The following is a description of a gene set: Any process that modulates the frequency, rate or extent of kinase activity, the catalysis of the transfer of a phosphate group, usually from ATP, to a substrate molecule. studied in species Mus musculus Mouse Gene Set: GOBP_REGULATION_OF_KINASE_ACTIVITY, and this is the list of marker genes: Cdk12, Tlr1, Taok3, Spry4, Macroh2a1, Wnt3a, Magi3, F2, Cdc37, Cdk5, Hhex, Nf1, Cep43, Stradb, Hyal2, Ern2, Midn, Ajuba, Tlr6, Gstp1, Edn3, Ttbk1, Tenm1, Dlg1, Ptpn22, Agt, Nhlrc1, Jtb, Pdgfb, Ubash3b, Notch2, Cdk5rap3, Spry2, Cdkn2a, Fgf18, Ptpn1, Traf6, Lilrb4b, Nppa, Efna1, Lime1, Fabp4, Sirt1, Shb, Cass4, Ptprj, Adam17, Psmd10, Lrp6, Pdgfrb, Il1b, Inpp5k, Chrna3, Erbb2, Ppia, Zgpat, Nherf1, Spred1, Zeb2, Lyn, Spdye4a, Adam9, Tfap4, Stk11, Rbl1 (RB transcriptional corepressor like 1), App, Fbxw7, Hnrnpu, Epha1 (NCBI Gene Id 70581), Spdya, Cdk5r1, Prox1, Adra2a, Ntf3, Tsg101, Dusp10, Hras, Pdgfa, Mt3, Dab1, Fgfr1, Nrbf2, Rassf2, Dnaja1, Trib3, Ccnyl1, Camk1, Src, Lep, Smg8, Tab2, Nrxn1, Dab2ip, Vegfc (vascular endothelial growth factor C), Cd300a, Pkig (protein kinase inhibitor, gamma), Irgm2 (immunity-related GTPase family M member 2), Rasip1, Pycard, Ip6k2, Irgm1, Slc11a1, Thy1, Slc8a2, Rgs2, Fzd5, Abi1, Csf1, Prkrip1, Clspn, Gskip, Strada, Spry1, Snca, Htt, Tpd52l1, Map3k11, Sh3bp5, Mapk8ip3, Ccnd2, Lats2, Cblc, Sod1, Spatc1l, Mapk8ip1, Srcin1, Cdk5rap1, Sash1, Robo1 (NCBI Gene Id 436378), Cemip, Tcim, Vps25, Trpt1, Rapgef2, Agrn, Paqr3, Cab39, Trim27, Xrcc6, Angpt1, Socs5, Rb1, Fgf1, Kitl, Pde5a, Slc1a1, Rad50, Men1, Blm, Hmgcr, Ins1, Dnajc3 (DnaJ heat shock protein family (Hsp40) member C3), Ins2, Ptprb, Mmd, Map2k6, Lilrb4a, Rap2b, Adipoq, Inca1, Pik3ca, Irak1, Sez6l, Nox4, Tsacc (TSSK6 activating co-chaperone), Egf, Deptor, Apc, Cdkn1a, Tsc1, Aida, Rbl2, Chrna7, Flt1, Acp4, Tnfaip3, D1Pas1, Gadd45b, Csf1r (colony stimulating factor 1 receptor), Wwtr1, Dok7, Wnt5a, Ccnd3, Map3k5, Akt1s1, Lilra5, Wars1, Tsc2 (TSC complex subunit 2), Cdkn2c, Il3, Hmga2, Htr2b, Pkia, Ccl19-ps6, Apoe, Tnfsf11, Ptk2b, Itgb3, Ccl19, Vangl2, Ccl19-ps1, Zfp622, Gadd45a, Fcer1a, Tnfrsf11a, Errfi1, Slc8a3, Cripto, Akt1, Qars1, Map3k7, Prkag2 (NCBI Gene Id 73700), Unc119, Rps3, Tcl1, Snx9, Mcph1, Nup62, Prdx3, Ccn1, Adarb1 (NCBI Gene Id 76716), Lmo4, Gas6, Ang4, Axin1, Reln, Zfp91, Cdkn2d, Adcyap1, Arhgef5, Ccny, Dusp7, Ltf, Gadd45g, Traf2 (TNF receptor-associated factor 2), Mapt, Prkca, Pxn, Cav3 (caveolin 3), Pim1, Socs4, Fzd4, Thbs1, Dynapl1, Dynap, Dusp1, C1qtnf9, Prkch, Tirap, Adrb2, Ldb2, Dnaja3, Slamf8, Ddx3x, Tead1 (NCBI Gene Id 70301), Cox11, Ggnbp2, Prlr, Tgfb2, Ang, Syap1, Heg1, Gtpbp4, Blvra, Rap2c, Fgd4, Cib1, Map3k13, Nolc1, Mst1, Ccdc88a, Tigar, Abi2, Ntrk3, Bmp2, Hexim2, Nek10, Chi3l1, Ccl19-ps5, Chordc1, Insr, Map3k4, Neurl1a, Pik3cg, Map4k2, Pak1, Lrp8, Pdcd10, Igf1, Sez6, Nr2f2, Plk1, Pkib, Tspyl2, Mst1r, Map2k3, Npm1, Higd1a, P2rx7, Pik3r6, Chmp6, Ddr2, Gnaq, Gckr, Adar, Trem2, Adcy8, Psen1 (NCBI Gene Id 19164), Lrrk2, Ager, Nrg1, Grem1, Park7, Chp1, Cdkn2b, Fgf2, Nlrc5, Psrc1, Garem1, Cd74, Lats1, Ppp2r3c, Map3k10, Emp2 (epithelial membrane protein 2), Ankrd54 (ankyrin repeat domain 54), Aplp2 (NCBI Gene Id 11804), Drd4, Trib2, Fbxo7, Epha4, Ang6, Vldlr, Ptk6, Ldb1, Map2k1 (NCBI Gene Id 26395), Cdk5r2, Adra2b, Mllt1, Nedd9, Fgr, Ptpn2, Fgd2, Hspb1, Rhoa (NCBI Gene Id 51787), Wdr59, Cav1, Bccip, Jak2, Nf2, Ccl19-ps4, Rgcc, Ppp2ca, Tnf, Prkcd, Rtraf, Syk, Stk38, Maged1, Pten, Tnfrsf4, Irak3, Irs2, Pparg, Map3k1, Bcl10, Pkn1, Sesn2, Trib1, Rgs14, Mrnip, Mapre3, Taf7, Sfn, Gprc5a, Dbndd2, Myocd, Ptprt, Pdgfc (platelet-derived growth factor, C polypeptide), Ang5, Zfyve28, Tm9sf5, Il4, Cdkn1c, Cdc25b, Cacul1, Cimap3, Wnk4, Uchl1, Igtp, Fem1a, Ppm1e, Kat2b, Rap1a (NCBI Gene Id 99734), Egfr, Pih1d1, Adra2c, Map2k4, Abi3, Traf4, Kif14, Dusp22, Gprc5b, Xrcc5, Cd24a, Iqgap1, Als2, Cd40, Smpd1, Eef1a2, Mtor, Tpx2, Ceacam1, Uvrag, Fbn1, Gstp2, Ptpro, Ccr7, Card10, Ccl19-ps3, Il34, Stox1, Mre11a, Slc8a1, Tlr4, Daxx, Map3k12, Hgs, Prkar1a, Mvp, Sfrp5, Ulk4, Ptprc, Rasgrp1, Ang2, Gpr39 (G protein-coupled receptor 39), Ect2, Ppm1f, Sfrp1, Nprl2, Map2k7, Gstp3, Hipk3, Pik3r5, Prkn, Kit, Ptprh, Mstn, Synpo2 (synaptopodin 2), Pibf1, Large1, Firrm, Pdcd4 (programmed cell death 4), Gstp-ps, Dstyk, Abl1, Ptpn6, Agap2, Psen2, Map2k2 (mitogen-activated protein kinase kinase 2), Dusp3, Sez6l2, Ifng, Cd4, Mmd2, Ereg, Dtnbp1, Coro1c (NCBI Gene Id 23790), Ezh2, Tab1, Wee2, Ccnd1, Erp29, Gba1 (NCBI Gene Id 14466), Cep85, Cops8, Dusp19, Dvl2, Gab1, Cartpt, Stil (NCBI Gene Id 230631), Cenpe, Etaa1, Edn1, Plec (NCBI Gene Id 381012), Ripk3, Epo, Sfrp2, Fzd8, Ksr1, Ptk2, Wdr24, Smyd3, Epm2a (NCBI Gene Id 380675), Ern1, Cdkn1b, Casp3 (caspase 3), Ralb, Itgb1bp1, Tom1l1, Nbn